The following is a description of a gene set: Human Gene Set: KEGG_MEDICUS_PATHOGEN_SALMONELLA_SOPB_TO_RHOG_SIGNALING_PATHWAY Salmonella SopB to RhoG signaling pathway. Pathway ID: N01133. Pathway type: Pathogen. Pathway class: nt06135 Cytoskeletal regulation (viruses and bacteria). Pathway Definition from KEGG: SopB -> ARHGEF26 -> RHOG -> ELMO species: Homo sapiens, and this is the list of marker genes: ARHGEF26, ELMO1, RHOG, ELMO3, ELMO2